The following is a description of a gene set: Human Gene Set: HP_NEUROFIBROMA Neurofibroma species: Homo sapiens A benign peripheral nerve sheath tumor that generally appears as a soft, skin-colored papule or small subcutaneous nodule. Individuals with neurofibromatosis can have numerous neurofibromas., and this is the list of marker genes: SDHC, PDGFB, SMARCB1, PIK3CA, AKT1, MLH1, SDHB, SUFU, SPRED1, TERT (telomerase reverse transcriptase), SMO, SMARCE1 (SWI/SNF related, matrix associated, actin dependent regulator of chromatin, subfamily e, member 1), TRAF7, KIT, SPTBN1, NF1, LRP1, NF2, BAP1